The following is a description of a gene set: Human Gene Set: REACTOME_MET_ACTIVATES_RAS_SIGNALING MET activates RAS signaling studied in species Homo sapiens, and this is the list of marker genes: MET, SHC1, SOS1, NRAS (NCBI Gene Id 4893), HRAS, HGF, RANBP10, KRAS, RANBP9, GRB2, MUC20